Given this list of marker genes VEGFA, HEG1, NOTCH1, CCBE1, EFNB2, CCM2, TBX20, ENG, PITX2 (paired like homeodomain 2), PROX1, here is a description of the gene set: Human Gene Set: GOBP_VENOUS_BLOOD_VESSEL_MORPHOGENESIS The process in which the anatomical structures of venous blood vessels are generated and organized. Veins are blood vessels that transport blood from the body and its organs to the heart. studied in species Homo sapiens